Given this list of marker genes Arsa, Sts, Arsi, Sumf2, Sumf1, Arsj, Arsb, Arsk, Arsg, here is a description of the gene set: studied in species Mus musculus The activation of arylsulfatases Mouse Gene Set: REACTOME_THE_ACTIVATION_OF_ARYLSULFATASES